The following is a description of a gene set: A developmental process, independent of morphogenetic (shape) change, that is required for an anatomical structure, cell or cellular component to attain its fully functional state. studied in species Mus musculus Mouse Gene Set: GOBP_DEVELOPMENTAL_MATURATION, and this is the list of marker genes: Spinkl, Kctd9, Akt1, Svs3b, B4galt5, Tmprss12, Zar1, Runx3, Semg1 (NCBI Gene Id 99448), Vsx1, Ghrhr, Kcnq2, Nfatc4, Runx1, Palm, Dab1, Map1b, Btk, Washc1, Rab38, Gm15915, Dld, Ptgs2, Rps6ka2, Ropn1, Actn3, Vegfa, Tdrd1, Pth, Ccr6, Ereg, Akr1b1, Fat4, Ltf, Neurog2, Lsm14b, Sez6, Catsperd (NCBI Gene Id 70944), Pgr, Slc24a4, Ccnb1, Tal1, Rec8, Farp2, Tbx6, Catsper4 (NCBI Gene Id 329954), Wee2, Dsg4, Hid1, Rb1, Tdrkh, Trip13, Ddit3, Erbb4, Foxo3, Mos, Gm36723, Calca, Slc26a6, Slfn14, Ier3ip1, Bcan, Ebp, Cabyr, Gata2, Kif14, Zdhhc20, Snx27, Stxbp1, Arhgef15, Nemp1, Opa1, Mir132, Fgf7, Defb37, Hes5, Syt4, Pmp22, Sox10, C1ql1, Kcnb1, Tcp11x2, Ercc2, Ift80, Asxl2, Kcnq3, Bhlha15, Snx19, Abhd2, Zdhhc15, Bloc1s5, Atp6v0a1, Cntn2, Atp6v1c1, Pld6, Disc1, Neurl1a, Notch1, Wnt5a, Slc9a6, Fermt1, App, Cntnap2, Rhoa, Epb42, Fgf22, Nom1, Mir133b (NCBI Gene Id 723817), Ascl1, Cdkn1c, Hoxb13, Adamts12, B4galt6, Atp6v1d, Gsk3b, Catspere2, Atp6v0d1, Thbs3, Ctnnb1, Fbxo5, Ptbp3, Oosp2, Svs3a, Ap3d1, Rac2, Tut7, Ryr1, Nrg2, Klf1, Msx2, Kdm1a, Gldn, Shank1, Nrxn1, Nox1, Dab2ip, Edn1, Gsdma3, Fam20c, Fgfr3, Angptl8, Tgfb1, Plxnb1, Rflnb, Chrdl1, Pla2g10, Mtor, Catsperz, Sclt1, Adgrl1, Trim58, Adgrb3, Dleu2, Irx5, Sirt2, Fzd5, Igf1, Lyl1, Akap5, Bnc1, Ythdf2, Atp6v1g1, Flvcr1, Nlgn1, Atp6v1g2, Nfix, Clstn1, Ccl21a (C-C motif chemokine ligand 21 (serine)), Catsper3, Brca2, Slc22a14, Enpp1, Sez6l (NCBI Gene Id 56747), C1ql2, Atp6v1b1, Spg21, Fbxo41, Lhx6, Ntn4, Ankle1, Snapin, Pde3a, Lrrk2, Rab3a, Atp6v0c, Igsf9, Rere, Efcab9, Cdh5, Zbtb16, Pth1r, Nrn1, Ropn1l (ropporin 1-like), Plcb1, Trpv1, Catsperb, Six3, Pfn1, Epha8, Foxa1, Sema7a, Ext1 (NCBI Gene Id 14042), Catsper2, Sez6l2, Tcp11, Igsf21, Kcnip2, Kcne1, Pcsk4, Gja1, Tmigd1, Hes1, Nrcam, Defb1, Rnd1, Cftr, Bloodlinc, C2cd6, Spink1, Bmp2, Gdf11, Ccdc39, Aldh1a2, Tdrd5, Atp6v1e1, Ccdc154, Unc13a, Ank3, Grem1, Cx3cr1, Rxfp2, Tut4, Ppp2r1a, Rbpj, Atp6ap2, Hnrnpk, Cdk5r2, Picalm, Zar1l, Ap1m1, Kcnma1, Brd1, Nf1, Bsph1, Psen1, Ankrd17, Rock1, Nfia, Mir212, Cspg4, Esr2 (estrogen receptor 2 (beta)), Hoxa5, Mmp2, Sox8, Fem1b, Il15, Dmc1, Grin1, Bcl11a (BCL11 transcription factor A), Pdgfb, Lgi4, Ret, Vezt, Sybu, Galnt3, Gal, Grip2, Myo5a, Diaph3, Bap1, Prkaca (protein kinase, cAMP dependent, catalytic, alpha), Catspere1, Slc17a7, Baiap3, Dchs1, Cacna1a, Nr4a2, Barx2, Tfcp2l1, Grb14, Pparg, Anapc2, Aurka, Hba-x, Ap1g1, Atp6v1g3, Runx2, Wdr77, Pla2g3, Washc5, Abl2, Id2, Fam210b, Dlg4, Nfasc, Wnt1, Mbtps2, Nsun2, C3, Clcn3, Foxj1, Cebpa, Atp6ap1, Ccl19, Cdc25b, Rfx3, Nefl, Dazl, Tusc2, Mreg, G6pd2, Dlg2, Anks1, Smim45 (NCBI Gene Id 76505), Atp6v1b2, Atp6v0e2, Fgfr1, Klf2, Epo, Il21, Pou2f2, Scarf1, Atp6v0a4, Insl3, Cst5, Zbtb7a, Pebp1, Ppard, Ano6, Myoc, Xylt1, Camk2b, Krtap21-1, Cbfb, Pax2, Map3k13, Cdh3, Heatr3, Kdr, Tgfb2, Atp6v1h, Rflna, Dag1, Zdhhc2, Hif1a, Phospho1, Neurod2 (neurogenic differentiation 2), Gba1, Pten, Bloc1s3, Tmem79 (NCBI Gene Id 71925), Ednrb, Vps35, Cd63, Cdk5r1, Xbp1, Actl6b, G6pdx, Psen2, Bfsp2, Nppc, Ihh, Bsph2, Pabpc1l, Axl, H3f3a, Rac3, C1qa, Atp6v1a, Sptbn4, Robo2, Tdrd7, Cdkn1a, Ctsl, Reln, Ptk2b, Iqcf1, Lnx1, Ngf, Ankrd27, Ednra, Snx10, Bfsp1, Shb, Tdrd6, Cntnap1, Adam7, Bcl2, Adamts7, Bloc1s6, Lep, Ago2, Npr2, Ywhaz, Dlgap4, Slc26a3, Rock2, Rab32, Hdac6, Tyms, Trpc4ap, Gata3, L3mbtl3, Sema4d, Srrm4, Gnaq, Arcn1, Mecp2, Reck, Epas1, Gpat4, Sox18, Cend1, Maea, Clec7a, Cdc20, Rac1, Lcn6, Ren1, Atp6v1f, S1pr1, Wnt10b, Tssk3, Rnase9, Fev, Septin4